Given this list of marker genes KCNG3, PITX2, RCC2, BCL6, CCDC126, TLNRD1, CHAD, ATP1B3, HSPA9, RBM7, TRPC4AP, PIK3IP1 (NCBI Gene Id 113791), BCL2L11, RNFT1, BTBD3, RGS16, CREB3, PPL, RELL2, ABCB6, VAPB, CREBRF, RNF5, HOXA2, PPT2, DLL4, ZSWIM9, LIG1, SLC6A1, ASCL1, TLN1, EIF1, GRK6, FHOD1, TIMM10, BMP2, GPM6B, KLF9, SLC12A5, PTPRF, SLC37A4, ITCH, GADD45B, GAPDH, AIFM3, PPP1R3B, KDM3A, SNX5, EMC1, KLHL35, PTPRJ, RORA, SELENOM, CSMD3, ENO1, PPP1R3C, MRTO4 (MRT4 homolog, ribosome maturation factor), BRWD3, CITED2, MRPL40, MEF2C, LRRTM1, SRSF6, EED, PDP2 (pyruvate dehydrogenase phosphatase catalytic subunit 2), PITPNC1, ZNF800, EIF2AK3, C11orf71 (chromosome 11 open reading frame 71), CDC42EP2, JADE1, NAV2, DERL3, TSKU, HMGN2, LDHA, CACNA2D2, FGF10, USF2, CBX8, RXRB, SLC26A10P, ZNF827, HNRNPUL1, TIAM1 (NCBI Gene Id 7074), IGF2BP3, XRN2, CAVIN1, SOX2, HPCAL4, EN1, IL1RAPL1, LHX2, SEC31A, PSD, UBR4, KICS2, DSCAML1, CA9, PNOC, LTBP1, ASPHD1, KMT2E, SLITRK4, BAHD1, ONECUT1, OSER1, PRDM13, ERO1A, CLSTN3, MEA1, SLC6A7, BCL11B, MACO1, BRSK2, INSM1, ALDH1A2, MICAL2, ARL5B, DERL1, FGF11 (fibroblast growth factor 11), TSSK3, RIMKLA, PRKAR2A, ARX, ARRDC3, E2F3, P3H3, HBEGF, NPAS2, TRIM33, BNIP2, NRBF2, FOXO4, PRR7, ELOVL6, ZBTB37, DOT1L, P4HA1, HIF1A, FCHSD2, MPL, PDK3, AGAP1, MCM8, DDX4, PROK2, TIAL1, YBX1, SRF, JADE2, GOLT1B, BCL2, PSME3, EPHB3, FAM114A1, PLPP5, HIRA, BHLHE41, PPM1E, IRX4, SLC39A7, NUP98, SLC6A12, PIGW, ZBTB47, PABPC1, NXPH4, SLC12A4, AGPAT1, NT5DC2, NR1D1, TBC1D20, NCAPH2, TEF, PNLDC1, MAX, FKBP3, VEGFA, IRF2BP1, SLC9A5, HYAL2, PHF12, SCYL1, PRDX4, NRF1 (NCBI Gene Id 4899), QRICH1, TMEM132E-DT, BMAL1, SOX14 (NCBI Gene Id 8403), COPZ1, DAP, SORCS3, CHMP4B, C15orf39, TWIST1, PIM1, LHX5, ZZZ3, ARPC2, TLE3, AK3, ERF, MARCKSL1, KLHDC3, LMF2, SLC2A1, KPNB1, RECQL, PRIMA1, WDR1, HMGA1, BCL11A, IPO13, CIART, RWDD2A, BMP6, HDAC3, TET2, PSMD5, USP4, PGM3, PDGFB, TMEM132E, ATL2, ENTPD7 (NCBI Gene Id 57089), PHLPP1, STMN1, ERLIN1, WEE1, PTGES3, FAM162A, RCOR2, SLC2A10, RTN4R (reticulon 4 receptor), HIF3A, EPO, IKZF2, TRMT6 (NCBI Gene Id 51605), LRP8, PES1, MYO19, TAOK2, SLC4A11, KTN1, FGF17 (fibroblast growth factor 17), PATZ1 (POZ/BTB and AT hook containing zinc finger 1), RPIA, MGME1, KLF11, here is a description of the gene set: Human Gene Set: HIF1_Q5 Genes having at least one occurrence of the motif CGTACGTGCNGB in the regions spanning 4 kb centered on their transcription starting sites. This matches the HIF1A transcription factor binding site V$HIF1_Q5 (v7.4 TRANSFAC). studied in species Homo sapiens